Given this list of marker genes LAT2, TRAFD1, HSD17B6, EMP3, GEM, RELB, CST6, CTTN, BIK, THBS1, CABP1, DUSP5, OGG1, KLHL22, ICAM1, LDB1, CDKN1A, ADRB2, HOMER3, UROD, EPHB6, MCAM, HSPB8, CXCL8 (C-X-C motif chemokine ligand 8), N4BP3, PLAU, NAGK, ISG20, ATF3, TIMP4, GDF15, PDGFB, PPP1R15A, SPHK1, PLPPR2, ULBP2, RNF25, ECM1, FOXD1, TUFT1, OASL, CHAC1, TRIM8, APOBEC3B, CAV1, here is a description of the gene set: species: Homo sapiens from publication Sagiv E, Starr A, Rozovski U, Khosravi R, Altevogt P, Wang T, Arber N (PMID 18413748) Genes down-regulated in HT29 cells (colon cancer) after knockdown of CD24 by both RNAi and monoclonal antibodies. CD24 is a potential oncogene reported to be overexpressed in a large variety of human malignancies. We have shown that CD24 is overexpressed in 90% of colorectal tumors at a fairly early stage in the multistep process of carcinogenesis. Anti-CD24 monoclonal antibodies (mAb) induce a significant growth inhibition in colorectal and pancreatic cancer cell lines that express the protein. This study is designed to investigate further the effects of CD24 down-regulation using mAb or small interfering RNA in vitro and in vivo. Western blot analysis showed that anti-CD24 mAb induced CD24 protein down-regulation through lysosomal degradation. mAb augmented growth inhibition in combination with five classic chemotherapies. Xenograft models in vivo showed that tumor growth was significantly reduced in mAb-treated mice. Similarly, stable growth inhibition of cancer cell lines was achieved by down-regulation of CD24 expression using short hairpin RNA (shRNA). The produced clones proliferated more slowly, reached lower saturation densities, and showed impaired motility. Most importantly, down-regulation of CD24 retarded tumorigenicity of human cancer cell lines in nude mice. Microarray analysis revealed a similar pattern of gene expression alterations when cells were subjected to anti-CD24 mAb or shRNA. Genes in the Ras pathway, mitogen-activated protein kinase, or BCL-2 family and others of oncogenic association were frequently down-regulated. As a putative new oncogene that is overexpressed in gastrointestinal malignancies early in the carcinogenesis process, CD24 is a potential target for early intervention in the prevention and treatment of cancer. Human Gene Set: SAGIV_CD24_TARGETS_DN